The following is a description of a gene set: Human Gene Set: BALLIF_DEVELOPMENTAL_DISABILITY_P16_P12_DELETION studied in species Homo sapiens from publication Ballif BC, Hornor SA, Jenkins E, Madan-Khetarpal S, Surti U, Jackson KE, Asamoah A, Brock PL, Gowans GC, Conway RL, Graham JM Jr, Medne L, Zackai EH, Shaikh TH, Geoghegan J, Selzer RR, Eis PS, Bejjani BA, Shaffer LG (PMID 17704777) Candidate genes in the pericentromeric microdeletion in 16p11.2-p12.2 associated with developmental disabilities. We have identified a recurrent de novo pericentromeric deletion in 16p11.2-p12.2 in four individuals with developmental disabilities by microarray-based comparative genomic hybridization analysis. The identification of common clinical features in these four individuals along with the characterization of complex segmental duplications flanking the deletion regions suggests that nonallelic homologous recombination mediated these rearrangements and that deletions in 16p11.2-p12.2 constitute a previously undescribed syndrome., and this is the list of marker genes: COG7, PRKCB, ATP2A1, IL4R, ALDOA, SCNN1G, CLN3, TBX6, SCNN1B, OTOA, IL21R, KDM8, SLC5A11 (solute carrier family 5 member 11)